The following is a description of a gene set: species: Homo sapiens from publication Chen Y, Wang X (PMID 31504780) Human Gene Set: MIR5007_3P Genes predicted to be targets of miRBase v22 microRNA hsa-miR-5007-3p in miRDB v6.0 with MirTarget v4 prediction scores > 80 (high confidence targets)., and this is the list of marker genes: PRAG1, RAI1, HAPLN1, CES5A, UTY, CASD1, CECR2, ADGRL4, ABCC9, ARFGEF2, ELOVL7, RBM27, MRPL35 (NCBI Gene Id 64980), NEMP1, CA2, OTUD6B, TRDMT1, TAC3, CADM2, PTPRC, METTL23, CPNE3, STEAP2, P2RY1, CNN3, ZBTB10, DCUN1D1, SGIP1, RANBP3, KLHL4, VLDLR, TMEM30A, TMEM114, CCDC47, LMO7DN, SLC17A6 (NCBI Gene Id 57084), SLC10A7 (solute carrier family 10 member 7), RPL17-C18orf32, CXADR, HERPUD2, TBC1D8B, TMEM35B, CXCL11, GAPT, SLC19A2, RBL2, ZNF770, EDNRA, SLC30A10, ARHGEF33, SENP2, RANBP3L, NPTX1, TDRD15, RAB4A, C18orf32, DCUN1D5, SIGLEC6, OGT, ST8SIA4, GABRA4, AP3B1, ZC3H6, SPATA6, FZD3, SS18L1, RNF145, PCDH20, SNURF, PIKFYVE, LMOD2, SH2D1A, SCYL2, MICU3, PROSER1, MYO15A, ZNF585B, STOX2, AFG3L2, AP1M2, CCSER1, CBLN4, AVL9, SEC24B, CNTRL, ZNF302 (NCBI Gene Id 82167), STXBP6, TMEM265, FBXL3, ADGRL3, HOXC5, MPZL2, SLC7A2, PREX2, SLC33A1, PFN2, PAK2, IFT81, TOMM5, LRP12, ZBTB1, PJA2 (praja ring finger ubiquitin ligase 2), AFG2A, KCNH2, GRIA4, NLGN4Y, RBMS3, EVI5, NEUROG1, VPS13C, CCNT1, TMCC3, TRMT1L, RORA, BCOR, MSI2, ADGRB3, ZEB2, SLC25A32, TPMT, MAGEB6, NLK